Given this list of marker genes PTGER2, SLC3A2, SKOR1, COL13A1, MRPL43, TRIM68, FRAS1, UNC5CL, KDM8, SKIC8, KRT37, TSPO2, APOBEC2, TARBP1 (NCBI Gene Id 6894), STX5, PRCC, FEZF1, KRT35, TWNK, KRT31, ISG20L2, PRUNE2, POU3F4, NFYA, PAX9, KRT13, KRT38, PCGF5, HMGN4, NXF1, PTPRE, EGLN3, HMX2, NFIB, HDGF, CCNA1, ISL2, PTGDR, KRT36, LHX1, FOXB2, ZNF184, CYP2R1, BTN1A1, CD8A, SEMA4G, CRABP2, NTRK1, IREB2, CALCA, SPART, KRT1, NETO2, MRPL24, MEOX2 (NCBI Gene Id 4223), SH2D2A, NEIL2, NKX2-8, AATF, MELK, CMTM3, WDR74, PRR15, EYA4, BARHL2, ERCC6, ETFA, SLC2A9 (NCBI Gene Id 56606), NKX2-1 (NCBI Gene Id 7080), CHRM1, ZBTB3, SALL1, CLRN3, RMND5A, PHACTR2, KRT32, WDR1, PCDH7, KIF20B, NES, GATA4, FOXI2, KRT33A, ADARB2, NIPSNAP3B, KRT2 (NCBI Gene Id 3849), ONECUT1, IQCH, PCDH19, KRT33B, TBX20, KCNMA1, CRABP1, NIPSNAP3A, ONECUT2, DNAJA4, KRT34, TAF6L, BUB3, POLR2G, LHX9, FDFT1, here is a description of the gene set: Genes with hypermethylated DNA in all four esophageal squamous cell carcinoma (ESCC) lines analyzed. Epigenetic alterations and the resulting inactivation of tumor suppressor genes often contribute to the development of various cancers. To identify novel candidates that may be silenced by aberrant methylation in esophageal squamous-cell carcinoma (ESCC), we analysed ESCC cell lines by a recently developed method known as bacterial artificial chromosome array-based methylated CpG island amplification (BAMCA), and selected candidates through BAMCA-assisted strategy. In the course of this program, we identified frequent CpG methylation-dependent silencing of the gene encoding cellular retinoic acid binding protein 1 (CRABP1) in our panel of ESCC cell lines. Expression of CRABP1 mRNA was restored in gene-silenced ESCC cells after treatment with 5-aza 2'-deoxycytidine. The DNA methylation status of the CRABP1 CpG island with clear promoter activity correlated inversely with expression of this gene. CpG methylation of CRABP1 was frequently observed in primary ESCC tissues as well. Restoration of CRABP1 expression in ESCC cells lacking the protein reduced cell growth by inducing arrest at G(0)-G(1), whereas knockdown of the gene in cells expressing CRABP1 promoted cell growth. Among 113 primary ESCC tumors, the absence of immunoreactive CRABP1 was significantly associated with de-differentiation of cancer cells and with distant lymph-node metastases in the patients. These results indicate that CRABP1 appears to have a tumor-suppressor function in esophageal epithelium, and its epigenetic silencing may play a pivotal role during esophageal carcinogenesis. Its expression status in biopsies or resected tumors might serve as an index for identifying ESCC patients for whom combined therapeutic modalities would be recommended. studied in species Homo sapiens Human Gene Set: TANAKA_METHYLATED_IN_ESOPHAGEAL_CARCINOMA from publication Tanaka K, Imoto I, Inoue J, Kozaki K, Tsuda H, Shimada Y, Aiko S, Yoshizumi Y, Iwai T, Kawano T, Inazawa J (PMID 17438526)